The following is a description of a gene set: Any process that modulates the frequency, rate or extent of mitochondrial ATP synthesis coupled electron transport. studied in species Mus musculus Mouse Gene Set: GOBP_REGULATION_OF_MITOCHONDRIAL_ATP_SYNTHESIS_COUPLED_ELECTRON_TRANSPORT, and this is the list of marker genes: Ccnb1, Dnajc15, Cdk1, Chchd2-ps, Chchd2, Ccnb1-ps